Given this list of marker genes CREBBP, LFNG, NUMBL, DTX3, DTX4, KAT2A, APH1A, PTCRA, MFNG, PSEN1, RBPJ, RFNG, NOTCH1, DTX2, NUMB, HES5, KAT2B (NCBI Gene Id 8850), HDAC2, MAML3, DLL4, APH1B, MAML1, ADAM17, DTX3L, DTX1, JAG1 (jagged canonical Notch ligand 1), RBPJL, NCSTN, NOTCH4, NCOR2, DLL1, HDAC1, DLL3, HES1, PSEN2, INPP5K, NOTCH3, CTBP1, JAG2, DVL1 (dishevelled segment polarity protein 1), NOTCH2, DVL3, CTBP2, KCNJ5, DVL2, here is a description of the gene set: species: Homo sapiens Notch signaling Human Gene Set: WP_NOTCH_SIGNALING_WP268